Given this list of marker genes Lcor, Prdm4, Wiz, Per2, Nop56, Gata3 (GATA binding protein 3), Cbx1, Hsp90ab1, Prdm1, Ncoa6, Paxbp1, Lcorl, Prdm14, Cbx3, Zfp335, Prdm12, Ctnnb1, Resf1, Phf1, here is a description of the gene set: species: Mus musculus Mouse Gene Set: GOMF_HISTONE_METHYLTRANSFERASE_BINDING Binding to a histone methyltransferase enzyme.